The following is a description of a gene set: species: Homo sapiens Human Gene Set: chr6q16, and this is the list of marker genes: RNU4-70P, PNISR-AS1, MANEA-DT, MIR548AI, MIR2113, NPM1P10, RPS7P8, KRT18P50, BDH2P1, GPR63, ATF1P1, ENSG00000202283, MCHR2, ENSG00000300482, EPHA7, PNISR, HACE1, UFL1-AS1, SIM1-AS1, USP45, R3HDM2P2, EIF4EBP2P3, TSTD3, LINC02531, FAXC, GRIK2, ENSG00000304752, ENSG00000271860, MANEA, FHL5 (four and a half LIM domains 5), NDUFAF4, COPS5P1, LIN28B, PRDM13, LIN28B-AS1, RN7SL797P, RN7SL509P, ENSG00000221455, MCHR2-AS1, CCNC, NPM1P38, PRDX2P4 (NCBI Gene Id 442239), POU3F2, UFL1, ENSG00000287616, TYMSP1, MTCYBP36, FBXL4, COQ3, MMS22L, FUT9, KLHL32, ASCC3, EEF1GP6, SIM1, CYCSP17, ACTG1P18, RNU6-897P (RNA, U6 small nuclear 897, pseudogene)